The following is a description of a gene set: A process which occurs during viral translation, which involves a translational recoding mechanism called programmed ribosomal frameshifting. This causes the ribosome to alter its reading of the mRNA to an a different open reading frame to produce alternate viral proteins. Mouse Gene Set: GOBP_VIRAL_TRANSLATIONAL_FRAMESHIFTING studied in species Mus musculus, and this is the list of marker genes: Shfl, Oaz2, Oaz3, Oaz1, Peg10 (paternally expressed 10)